Given this list of marker genes Dct, Oca2, Slc45a2, Tyr (NCBI Gene Id 22173), Tyrp1, here is a description of the gene set: Mouse Gene Set: REACTOME_MELANIN_BIOSYNTHESIS species: Mus musculus Melanin biosynthesis